The following is a description of a gene set: SARS-CoV-2 modulates host translation machinery species: Homo sapiens Human Gene Set: REACTOME_SARS_COV_2_MODULATES_HOST_TRANSLATION_MACHINERY, and this is the list of marker genes: RPS5, DDX20, RPS14, GEMIN4, RPS25, RPSA, RPS27 (ribosomal protein S27), RPS15A, RPS9, RPS18, RPS4X, GEMIN5, RPS20, SNRPD3, RPS7, RPS13, RPS12, RPS27A, SNRPB, RPS28, RPS29, SNRPD1, RPS27L, GEMIN7, RPS6, GEMIN8, FAU, RPS10, RPS19, SNRPF, RPS17, SNRPD2, SMN1, RPS8, RPS16, RPS4Y2, SMN2, RPS3A, RPS24, RPS23, SNRPE, GEMIN6, SNRPG, RPS4Y1, RPS21, RPS2, RPS26, RPS15, GEMIN2, RPS11, RPS3